The following is a description of a gene set: Mouse Gene Set: GOCC_AMINOACYL_TRNA_SYNTHETASE_MULTIENZYME_COMPLEX species: Mus musculus A multienzyme complex found in all multicellular eukaryotes composed of eight proteins with aminoacyl-tRNA synthetase activities (abbreviated as: ArgRS, AspRS, GluProRS, GlnRS, IleRS, LeuRS, LysRS, MetRS where RS is the enzyme, preceded by the amino acid it uses as a substrate) as well as three non-synthetase proteins (p43, p38, and p18) with diverse functions. Several of these subunits are known dimers, so the total polypeptide count in the multisynthetase complex is at least fifteen. All of the enzymes in this assembly catalyze the same reaction, the covalent attachment of an amino acid to either the 2'- or 3'-hydroxyl of the 3'-terminal adenosine of tRNA, but using different substrates., and this is the list of marker genes: Rars1, Rpl5, Lars1, Aimp1, Iars1, Aimp2, Eprs1, Dars1, Eef1e1, Qars1, Kars1, Mars1